The following is a description of a gene set: Human Gene Set: GSE15930_STIM_VS_STIM_AND_IFNAB_72H_CD8_T_CELL_UP Genes up-regulated in comparison of unstimulated CD8 T cells at 72 h versus CD8 T cells at 72 h after stimulation with antigen-B7-1. Differentiation of naive CD8 T cells into cytotoxic effector cells requires three distinct signals- antigen (signal 1), costimulation -B7-1 (signal 2) and cytokine, either interleukin-12 or interferon-a/b (signal 3). Interaction of naive CD8 T cells with antigen and B7-1 programs cell division and proliferation whereas the presence of cytokines- IL-12 or IFNa/b promote survival, differentiation and memory establishment. In the absence of signal 3, the cells interacting with antigen/B7-1 undergo tolerance induction. The objective of this study was to elucidate the mechanisms how the provision of signal 3 promotes differentiation and averts tolerance induction in CD8 T cells. Trichostatin A is a pharmacological agent that inhibits histone deacetylase activity, hence regulating chromatin structure and gene expression and differentiation in many cell types. Gene signature profiles of IL-12, IFNa/b and trichostatin A stimulated cells were compared to elucidate the molecular mechanisms of gene regulation. Oligonucleotide microarray analysis is carried out to determine the extent and molecular nature of the CD8 T cell differentiation program induced by IL-12 or IFNa/b in concert with antigen and B7-1 signal. from publication Agarwal P, Raghavan A, Nandiwada SL, Curtsinger JM, Bohjanen PR, Mueller DL, Mescher MF (PMID 19592655) species: Homo sapiens, and this is the list of marker genes: G6PC2, FGD1, LAMA5, OMD, DPT, ATP5PF, B3GAT3, IRAG1, CRP, CCN1 (cellular communication network factor 1), IKBKB, IQGAP2 (NCBI Gene Id 10788), FUT4, HSPG2, FCER2, H1-4, PLG, KCNK3, FOLR2, FZD9, DNAJA2, IL9, EPHB2 (NCBI Gene Id 50980), IQGAP3, MYRF, DHH, TMT1A, LCAT, PEMT, CYP4A22, GABPA, RIPOR2, FBXO15, GFM2, GABRB1, KLHL21, IGFBP6, MPP3, PDGFRB, PLAU, RACK1, GNPTG, COASY, H2BC18 (H2B clustered histone 18), RIOX2, FZD6, ABRACL, LCT, KMT2E, IMPA1, PSMC1, EPHB6, EIF2B4, ARG1, CIDEC, HTR3A, H3C7, TDRP, POU3F3, ODF1 (outer dense fiber of sperm tails 1), PROS1, AMH, EGLN2, EFNA3, PREB, HCRT, MPHOSPH9, PNLIPRP1, BMP15, GAA, KRT2, MTHFR, GABARAPL1, OPRD1, CLOCK, PEPD, NEDD8, NTN1, DMTF1, G0S2 (G0/G1 switch 2), ATXN1, GALK2, PCBD2, HLA-DOB, POP4, HOXC5, INHBC, OTULINL, ECE1, MAST2, ATP6AP1, DNAJC9, AMBN, IL1A, MEF2D, NLRX1, MORC4, P3H3, ACO1, LTBP3, MYL6B, OR6A2, CLEC4D, GJC1, CD14, B4GALNT1, TENM1, PKNOX1, KLF12, EEF1AKMT1, GPM6B, PCDH7, PROP1, CCKBR, APBB1IP, GP9, CRISP3, NAA80, ANKZF1, KRT12, GBA2, FCRLA, MC1R, NT5DC3, NHSL2, CALCB, FRAT2, FAM151A, ADORA2A, AIRE, MARK4, EPS15, PGAM2, FUT1, BARX1, GCDH, ARF5, MYO1C, CDH13, KIF3C, CALCRL, ATXN7L3, CDKN1B, BUD31, MCUR1, GLRB, LRP6, PENK, CREBBP, MEST, CDKN2D, PNMT, PHKG1, HTR2C, IRS2, PLAC9, ADH1C, METTL18, APBA2, HSD17B11, CNN2, GATA1, FBXW2 (F-box and WD repeat domain containing 2), GAMT, F8, ANKRD13A, CAT, GPSM3, IFNB1, CBFA2T3, MFNG, BLK, BPIFA2, MYT1, GNA14, FLT3, GJA4, FKBP10, DMRTB1, MYH14, MLLT1, CA3, ANKRD10, IREB2 (NCBI Gene Id 3658), KRTDAP, COL8A1, AXIN1, DPF3, ADRB3, FABP9, GPRASP1, LRP5, ASF1B (NCBI Gene Id 55723), CACNA1H, EMP3, INPP1, METTL17, LAMA4, BAZ2A